The following is a description of a gene set: Activation of PRC2.2 by ubiquitination of H2AK119 in germline genes. Pathway ID: N01614. Pathway type: Reference. Pathway class: nt06523 Epigenetic regulation by Polycomb complexes. studied in species Homo sapiens Pathway Definition from KEGG: PRC1.6 -- (MGA,MAX+L3MBTL2+E2F6) -- H2AK119+UB -> PRC2.2 Human Gene Set: KEGG_MEDICUS_REFERENCE_ACTIVATION_OF_PRC2.2_BY_UBIQUITINATION_OF_H2AK119_IN_GERMLINE_GENES, and this is the list of marker genes: E2F6, CBX3, HDAC1, EHMT1, MGA, UBB, AEBP2, RING1, SUZ12, EZH2, RBBP4 (RB binding protein 4, chromatin remodeling factor), RYBP, EZH1, HDAC2, MAX, WDR5, RBBP7, RNF2, H2AC1, JARID2 (NCBI Gene Id 3720), EHMT2, EED, H2AC4, TFDP1, L3MBTL2, YAF2, PCGF6